Given this list of marker genes Usp9x, Usp46, Cd19 (NCBI Gene Id 12478, CD19 antigen), Cd160, Lilrb4a, Btnl2, Cd226, Malt1, Ptpn22, Dgkz, Dusp3, Cyld (NCBI Gene Id 74256), Thy1, Cd300a, Prnp, Ptprj, Pawr, Pvrig, Ptprc, Cmtm3, Prkd2, Lipa, Cd22, Btn2a2, Ubr2, Foxp1, Nectin2, Stap1, Cd81, Ikbkg, Nfam1, Plcl2, Slc39a10, Sla2, Cblb, Trat1, Fcrl5, Ccr7, Fcmr, Lck, Rela, Card11, Btrc, Kcnn4, Rc3h1, Bcl10, Rps3, Itpripl1, Gcsam, Rab29, Gps2, Laptm5, Lilrb4b, Tespa1, Sh2d1a, Nck1, Ptpn6, Lpxn (leupaxin), Lgals3, Ezr, Ubash3a, Ceacam1, Ptpn2, Dusp22, Lyn, Prkch, Ada, Usp12, Phpt1, Elf1 (NCBI Gene Id 13709), here is a description of the gene set: Any process that modulates the frequency, rate or extent of signaling pathways initiated by the cross-linking of an antigen receptor on a B- or T cell. Mouse Gene Set: GOBP_REGULATION_OF_ANTIGEN_RECEPTOR_MEDIATED_SIGNALING_PATHWAY studied in species Mus musculus